Given this list of marker genes SYT1, CACNA1B, SLC4A8, PPP3CA, NLGN1, here is a description of the gene set: Any process that activates or increases the frequency, rate or extent of synaptic vesicle exocytosis. species: Homo sapiens Human Gene Set: GOBP_POSITIVE_REGULATION_OF_SYNAPTIC_VESICLE_EXOCYTOSIS